The following is a description of a gene set: electronically inferred by orthology from the curated human pathway species: Mus musculus Reactome Pathway: Blood group systems biosynthesis This event has been computationally inferred from an event that has been demonstrated in another species.<p>The inference is based on the homology mapping from PANTHER. Briefly, reactions for which all involved PhysicalEntities (in input, output and catalyst) have a mapped orthologue/paralogue (for complexes at least 75% of components must have a mapping) are inferred to the other species. part of: Metabolism of carbohydrates and carbohydrate derivatives, and this is the list of marker genes: B4galnt2, B3galt4, Fut1, Fut4 (NCBI Gene Id 14345), Abo, B3galt2, St3gal4, Fut2, St6galnac6, St3gal3, Fut9, B3galt5